The following is a description of a gene set: studied in species Mus musculus Integrin signaling Mouse Gene Set: REACTOME_INTEGRIN_SIGNALING, and this is the list of marker genes: Fgb, Akt1, Syk, Fn1, Itga2b, Rap1a, Vwf, Fga, Grb2, Csk, Sos1, Rap1b, Ptpn1, Src, Bcar1, Rapgef3, Pdpk1, Tln1, Rapgef4, Rasgrp1, Shc1, Rasgrp2, Crk, Fgg, Itgb3, Ptk2, Apbb1ip